Given this list of marker genes Lrp6, Dll4, Wnt5a, Bmp5, Tbx20, Bmp7, Notch1, Sos1, Flrt3 (NCBI Gene Id 77649), here is a description of the gene set: The process in which the anatomical structure of the pericardium is generated and organized. Mouse Gene Set: GOBP_PERICARDIUM_MORPHOGENESIS species: Mus musculus